The following is a description of a gene set: studied in species Mus musculus from publication Chen Y, Wang X (PMID 31504780) Mouse Gene Set: MIR_7221_5P Genes predicted to be targets of miRBase v22 microRNA mmu_miR_7221_5p in miRDB v6.0 with MirTarget v4 prediction scores > 80 (high confidence targets)., and this is the list of marker genes: Siglech, Scn3b, Golga1, Bfar, Smpd1, Pdgfa, Hpcal4, Cab39l, Gm14322, Crem, Bloc1s5, Zic1, Asxl2, Slc37a1, Mapkapk2, Sptssb, Otx2, Cstf3, Gm16405, Wbp1, Itga10, Prkch, Arcn1, Pde4b (NCBI Gene Id 97194), Ammecr1, Gpr155, Ctdspl2, Sp1, Gm16430, Fbxo22 (NCBI Gene Id 78764), Erg, Zfp708 (zinc finger protein 708), Zfand5, Tmem231, Slxl1, Zfp609, H2-M10.1, Ctr9, Hdgfl3, Scamp1, Ccdc106, Grk1 (G protein-coupled receptor kinase 1), Zfp398, Nbea, Tmem108, Ube2d2b, Ppargc1a, Kcnj3, Med14, Bcl2l15, Foxn2, Akap6, Smyd4, Mobp, Dok2, Cdk7, Gm6710, Abca9, Gcsam, Spata19, Trpm7, Dynlt5, Ola1, Kcnj14, Bend4, Gmfb, C130074G19Rik, Pdgfra, Timm17a, Ptprr, Zbtb10, Kcnt2, Rab3c, Yy2, Tgm6, Eeig2, Ckap5, Pate9, Cdca7l, Zfp451, Slc44a5, Rap1b, Slc24a2, Fgd4, Slc1a2, Cask (calcium/calmodulin dependent serine protein kinase), Cdk6, Dach1, Chrdl1, Fam120c (family with sequence similarity 120, member C)